The following is a description of a gene set: Human Gene Set: GOBP_DEOXYRIBONUCLEOSIDE_MONOPHOSPHATE_METABOLIC_PROCESS species: Homo sapiens The chemical reactions and pathways involving a deoxyribonucleoside monophosphate, a compound consisting of a nucleobase linked to a deoxyribose sugar esterified with phosphate on the sugar., and this is the list of marker genes: NT5C1A, NT5M, UPP2, SHMT1, NT5C (5', 3'-nucleotidase, cytosolic), TYMS, GUK1, PNP, GDA, ADA, DNPH1, DPYS, TK2, DPYD, UPP1, TK1, XDH (NCBI Gene Id 7498), DUT, TYMP, ADK, NT5C2, UPB1, DCTD, DGUOK, DCK